Given this list of marker genes OPRK1, SYT1, KCNB1, PINK1, CXCL12, CHRNB2, STX1A, OXT, CARTPT, GDNF (glial cell derived neurotrophic factor), NPY2R, GRK2, here is a description of the gene set: Human Gene Set: GOBP_POSITIVE_REGULATION_OF_CATECHOLAMINE_SECRETION species: Homo sapiens Any process that activates or increases the frequency, rate or extent of the regulated release of a catecholamine.